The following is a description of a gene set: studied in species Homo sapiens Reactome Pathway: Growth hormone receptor signaling part of: Cytokine Signaling in Immune system Growth hormone (Somatotropin or GH) is a key factor in determining lean body mass, stimulating the growth and metabolism of muscle, bone and cartilage cells, while reducing body fat. It has many other roles; it acts to regulate cell growth, differentiation, apoptosis, and reorganisation of the cytoskeleton, affecting diverse processes such as cardiac function, immune function, brain function, and aging. GH also has insulin-like effects such as stimulating amino acid transport, protein synthesis, glucose transport, and lipogenesis. The growth hormone receptor (GHR) is a a member of the cytokine receptor family. When the dimeric receptor binds GH it undergoes a conformational change which leads to phosphorylation of key tyrosine residues in its cytoplasmic domains and activation of associated tyrosine kinase JAK2. This leads to recruitment of signaling molecules such as STAT5 and Src family kinases such as Lyn leading to ERK activation. The signal is attenuated by association of Suppressor of Cytokine Signaling (SOCS) proteins and SHP phosphatases which bind to or dephosphorylate specific phosphorylated tyrosines on GHR/JAK. The availability of GHR on the cell surface is regulated by at least two processes; internalization and cleavage from the suface by metalloproteases., and this is the list of marker genes: JAK2, SOCS1, GH1, PRL, CSH1, PRLR, SH2B1, ADAM17, SOCS2, SOCS3, GH2, IRS2, IRS1, STAT3, STAT1, STAT5B, PTPN1, PTPN6, MAPK1, MAPK3, STAT5A, CISH (cytokine inducible SH2 containing protein), GHR, LYN